The following is a description of a gene set: species: Homo sapiens Human Gene Set: WP_8P231_COPY_NUMBER_VARIATION_SYNDROME 8p23.1 copy number variation syndrome, and this is the list of marker genes: CLDN23, FAM167A, TERF1, GATA4, MFHAS1, TNKS, CSTA, RP1L1, SLBP, FAM167A-AS1, SOX7, MTMR8, BLK, MSRA, DEFB136, MCRS1, NUMA1, NEIL2, FCGR2B, DEFB134, MEPE, TLR2, HEPACAM2, HSPD1, S100A10, CTSD, CGAS, NKX6-1, MTMR7, PPP1R3B, PRSS55, SLC35G5, CTNNB1, MTMR6, MAPK3, SLC2A4, FDFT1, PDX1, TLR4 (toll like receptor 4), TBX5, ERI1 (NCBI Gene Id 90459), FCGR2A, RAF1 (NCBI Gene Id 5894), AXIN1, MTMR9, PINX1, TERT (NCBI Gene Id 7015), C8orf74, MAPK1, CTSB, DEFB135, SGPL1, XKR6, BMP1